The following is a description of a gene set: Human Gene Set: GOBP_BUNDLE_OF_HIS_CELL_TO_PURKINJE_MYOCYTE_SIGNALING Any process that mediates the transfer of information from a bundle of His cardiomyocyte to a Purkinje myocyte. species: Homo sapiens, and this is the list of marker genes: GJA5, SCN5A, KCNA5, CACNA2D1, SCN10A, RANGRF, TRPM4